The following is a description of a gene set: Human Gene Set: GOBP_POSITIVE_REGULATION_OF_ENDOTHELIAL_CELL_DIFFERENTIATION Any process that activates or increases the frequency, rate or extent of endothelial cell differentiation. studied in species Homo sapiens, and this is the list of marker genes: MIR34A, BMP6, MIR199B, MIR21, ACVRL1, ETV2, BMP4, MIR181A2, MIR99B, CTNNB1, NOTCH1, MIR200C, GDF2, TMEM100, BTG1, MIR150, VEZF1, ATOH8, MIR181B1